The following is a description of a gene set: Genes predicted to be targets of miRBase v22 microRNA hsa-miR-4727-5p in miRDB v6.0 with MirTarget v4 prediction scores > 80 (high confidence targets). from publication Chen Y, Wang X (PMID 31504780) studied in species Homo sapiens Human Gene Set: MIR4727_5P, and this is the list of marker genes: RYK, HACE1, ETNPPL, BACE1, UBXN7, SLC16A12 (NCBI Gene Id 387700), NFKBIZ, RPS27A, ARCN1, WDR48, REPS2, BANF1, NKAIN2, CBFB, RIMS2, NCOR2, DDHD2, C9orf57, EFNA5, TENM1, KCNQ5, CCDC126, CSTF3, EML4, PPP1R1C, TXLNB, CCDC6, HOOK3, MOCS2, GRM5, LRATD1, ZFHX3, SLC6A6, FLNB, GGACT, NLGN1, ERICH6B, SCN8A, NCBP3, CD302, KLHDC10, YTHDF1, IGF2BP1, ST6GALNAC5, SHOC2, HMG20A, DPPA4, ZBTB10, SLC9A1, SEC22C, CIPC, LY75-CD302, EIPR1, GRID2, FAM78A, RAB23, PDPK1, SENP2, PTAR1, PFKFB4, IRF4, ACTR1A, KIAA0513, ODC1, NUP98, CNTN4, PPHLN1, VAPA (VAMP associated protein A), NPY2R, PRP4K, NFAT5, PAK5, RALB, TM9SF2, SLC25A14, HERC3, GARIN2, FUT4, L2HGDH, AGFG1, MBD5, MYT1L, UFL1, FAM168A, SYCE2, MAPK8, ADAMTS5, PSAP, CAMSAP2, ATRX, ADGRL3, CDK6, AMOT, THSD7B, PDAP1, BPTF, EIF5A2 (NCBI Gene Id 57114), SPRY4, WAPL, PFKFB3, SPRTN, EIF2S3, UBE2Z, REPS1, PAK2, TMEM178B, GNAS, SVOP, PTN, GP1BA (glycoprotein Ib platelet subunit alpha), NIPBL (NCBI Gene Id 25836), RNF144B, PIAS1, RAPH1, VASH1